Given this list of marker genes Atat1, Brpf3, Esco2 (establishment of sister chromatid cohesion N-acetyltransferase 2), Jade2, Clock, Kat6b, Nat8f3, Pygo2, Atf2, Gtf3c4, Cdyl, Esco1, Abhd14b, Crebbp, Ing3, Kat14, Tada2a, Usp22 (ubiquitin specific peptidase 22), Phf10, Brca2, Gtf2b, Med24, Meaf6, Brpf1, Ep300, Oga, Nap1l2, Jade1, Ing4, Msx3, Naa60, Mcm3ap, Brd1, Ncoa1, Kat5, Naa40, Taf9, Hat1, Mettl8, Kat7, Taf1, Bloc1s1, Taf10, Naa50, Kat2b, Kat2a, Kat8, Kat6a (NCBI Gene Id 60407), Nat8f7, Ncoa3, here is a description of the gene set: studied in species Mus musculus Catalysis of the reaction: acetyl-CoA + lysine in peptide = CoA + N-acetyl-lysine-peptide. The acetyl group is transferred to the nitrogen atom at position 6 of the lysine residue in the protein. Mouse Gene Set: GOMF_PROTEIN_LYSINE_ACETYLTRANSFERASE_ACTIVITY